Given this list of marker genes POM121, PIAS4, NUP98, NUP93, SUMO1, NUP188, NUP35, NUP54, NUP58, TRIM27 (NCBI Gene Id 5987), NUP37, NUP42, NUP133, NUP88, AAAS, UBE2I, PIAS1, NUP43, NUP160, SEC13, NDC1, MDM2, TPR, VHL (von Hippel-Lindau tumor suppressor), NUP214, NUP210, SEH1L, NUP85, NUP50, NUP155, PML, PIAS2, POM121C, NUP205, RAE1, NUP62, NUP107, RANBP2, NUP153, here is a description of the gene set: SUMOylation of ubiquitinylation proteins studied in species Homo sapiens Human Gene Set: REACTOME_SUMOYLATION_OF_UBIQUITINYLATION_PROTEINS